Given this list of marker genes AOX1 (NCBI Gene Id 316), ALDH1A1, CYP2W1, CYP2A6, BCO1, RPE65, DHRS4, RDH13, CYP1A1, CYP3A7, LRAT, DHRS9, ADH1A, AWAT2, SDR16C5, PNPLA4, RDH12, here is a description of the gene set: studied in species Homo sapiens Retinol metabolism Human Gene Set: WP_RETINOL_METABOLISM